Given this list of marker genes Yap1, Tead3, Tbx5, Tead2, Tead1, Tead4, Wwtr1 (WW domain containing transcription regulator 1, NCBI Gene Id 97064), Kat2b, here is a description of the gene set: Mouse Gene Set: REACTOME_YAP1_AND_WWTR1_TAZ_STIMULATED_GENE_EXPRESSION YAP1- and WWTR1 (TAZ)-stimulated gene expression species: Mus musculus